Given this list of marker genes HSD17B10, PUS1, METTL1, FTSJ1, ELP2, DUS3L, RPP25, ANKRD16, TRMT9B, TRMT10C, TRMT2B, TPRKB, RPUSD4, PUS10, ELP5 (elongator acetyltransferase complex subunit 5), TRMT1L (NCBI Gene Id 81627), ELP3, AKT1, TSEN15, TRMT12, METTL2B, TRNT1, TRMT13, KTI12, TRMT44, TYW3, TSEN2, QTRT1, TRMT11, QNG1, TRMT112, LAGE3, TRMU, TRMT10B, POP7, LCMT2, C2orf49, PUSL1, YRDC, PUS7, RPP14, TRDMT1, TRMT2A, TP53RK, CDKAL1, B3GNTL1, RPPH1, CLP1, THG1L, RPP21, ZBTB8OS, POP5, ELAC1, NSUN3, MTO1 (NCBI Gene Id 25821), TRMO, ADAT3, METTL8, DUS2, FARS2, TYW1B, GTPBP3, PRORP, ELP6, TRMT1, ADAT1 (adenosine deaminase tRNA specific 1), ELP4, FAM98B, PUS3, DTWD1, FAM98A, TYW5, DDX1, RTRAF, DTWD2, DPH3, TYW1, SARS1, LSM6, SSB, URM1, TRMT5, MOCS3, TRMT10A, QTRT2, TRUB2, DUS4L, METTL2A, THUMPD2, RPP38, TARBP1, TRPT1, TSEN54, TRIT1, GON7, POP4, CTU2, THADA (NCBI Gene Id 63892), GRSF1, OSGEP, TRMT61B, ADAT2, POP1, WDR6 (WD repeat domain 6), THUMPD1, KARS1, METTL6, TRUB1, DALRD3, ALKBH8, TRMT61A, PTCD1, TSEN34, CDK5RAP1, ELAC2, NSUN6, ALKBH1, RPP40, RPP25L, DUS1L, CTU1, SEPSECS, MTFMT, GTDC1, NSUN2, RTCB, OSGEPL1, RPP30, ELP1, WDR4, AARS1, BCDIN3D, THUMPD3, NAT10, TRMT6 (NCBI Gene Id 51605), here is a description of the gene set: Human Gene Set: GOBP_TRNA_PROCESSING species: Homo sapiens The process in which a pre-tRNA molecule is converted to a mature tRNA, ready for addition of an aminoacyl group.